Given this list of marker genes Musk, Slc18a3 (NCBI Gene Id 20508), Dctn1, Gsk3b, Agrn, here is a description of the gene set: Any process that activates or increases the frequency, rate or extent of neuromuscular junction development. studied in species Mus musculus Mouse Gene Set: GOBP_POSITIVE_REGULATION_OF_NEUROMUSCULAR_JUNCTION_DEVELOPMENT